Given this list of marker genes SMCHD1, SMC3, FZD2, CDC6, HDAC8, AR, DVL1, CDT1, BRD4, ORC4, ORC6, B3GLCT, FGFR2, CHRNG, MAB21L1, MYH3, HSD3B2, LIPE, ECEL1, CTCF, ORC1, WNT5A, RAD21, NR5A1 (NCBI Gene Id 2516), ROR2, CDC45, TWIST2, POR (cytochrome p450 oxidoreductase), PPP2R3C, TP63, IRF6 (interferon regulatory factor 6), VAC14, RAB3GAP2 (NCBI Gene Id 26114), NIPBL, RIPK4, SLC25A24, UBE3B, SMC1A, TAF6, ESR2, SETBP1, PMM2, FIG4, GMNN, DVL3, GAD1, here is a description of the gene set: An anomaly of the outer labia. Human Gene Set: HP_ABNORMAL_LABIA_MAJORA_MORPHOLOGY Abnormal labia majora morphology studied in species Homo sapiens